Given this list of marker genes MYCBP, MYC (MYC proto-oncogene, bHLH transcription factor), CMTR2, MORF4L1, KAT6A, NFIB, CHEK2, SMARCA2, ERBIN, TP53, MGA, H2AC16 (NCBI Gene Id 8332), MYCN, NSD1, MYBL1, PIK3CA, FBXW7, SMC1A, IL17RD (NCBI Gene Id 54756), KDM6B, FGFR4, KDM6A, ATRX, MYB, FGF16, ERBB2, EP300, FOXO3, AKT1, KMT2C, CNTN6, CREBBP, ARID5B, UHRF1, PTEN, H1-4, BRD1 (bromodomain containing 1), MAML3, ARID4B, BRCA1, ARID1A (NCBI Gene Id 8289), FOXP2, SETD2, NOTCH1, MAX, PRKDC, DTX4, INSRR, CTBP1, KANSL1, CEBPA, MAGI1, BCORL1, NCOR1, SMARCE1, JMJD1C, TLK1, HRAS, MAP2K2, RAF1, ATM, MAGI2, CHEK1, BCOR, SRCAP, here is a description of the gene set: Human Gene Set: WP_PATHWAYS_AFFECTED_IN_ADENOID_CYSTIC_CARCINOMA Pathways affected in adenoid cystic carcinoma species: Homo sapiens